The following is a description of a gene set: Reactome Pathway: Epigenetic regulation by WDR5-containing histone modifying complexes <p>WDR5 is a component of six histone methyltransferases and three histone acetyltransferases involved in epigenetic regulation of gene expression.</p><p>The WDR5 histone methyltransferase complexes (KMT2 complexes) include the Mixed Lineage Leukemia (MLL) 1-4, SET1A, and SET1B. All KMT2 complexes consist of a histone methyltransferase (KMT2A, KMT2B, KMT2C, KMT2D, SETD1A, or SETD1B, respectively) and the WRAD subcomplex composed of WDR5, RBBP5, ASH2L, and DPY30. The WRAD complex regulates the enzymatic activity of histone methyltransferases and enables their recruitment to chromatin. Additional transcription cofactors associate with each KMT2 histone methyltransferase complex, enabling their functional diversification. All KMT2 complexes methylate lysine K5 of histone H3 (K4 in mature histone H3 peptides, as the initiator methionine is removed), which is associated with transcriptional activation. Different KMT2 complexes preferentially monomethylate, dimethylate, or trimethylate H3K4, depending on the presence of accessory subunits, transcriptional co-factors, and posttranslational modifications. The KMT2A and KMT2B complexes preferentially methylate H3K4 at a limited number of target gene promoters, while KMT2C and KMT2D complexes preferentially methylate H3K4 at a limited number of target gene enhancers. SETD1A and SETD1B complexes are responsible for the bulk of cellular H3K4 methylation and show less target specificity. For a detailed overview, please refer to Cho et al. 2007, Song and Kingston 2008, Patel et al. 2009, Wang et al. 2009, Takahashi et al. 2011, Couture and Skiniotis 2013, van Nuland et al. 2013, Rao and Dou 2015, Klonou et al. 2021.</p><p>WDR5 is also a component of three histone acetyltransferase complexes, GCN5-ATAC, PCAF-ATAC, and MOF/KAT8-NSL. The role of WDR5 in epigenetic regulation of gene expression through histone acetylation is under investigation.</p><p>The KMT2C (MLL3) complex, together with the related KMT2D (MLL4) complex, is most similar to Drosophila Trr (Trithorax-related) and mediates hitone H3 lysine-4 (H3K4 - lysine 5 in nascent histone H3) monomethylation, with the establishment of the H3K4me1 epigenetic marks, at transcription enhancers throughout the human genome, with estimates ranging from approximately 12,000 to over 20,000 sites, depending on the cell type and developmental stage. While H3K4 monomethylation by MLL3 and MLL4 complexes may not be essential for expression of developmental genes, it is likely important for fine tuning of transcription levels and timing, both during normal development and in cancer. For review, please refer to Hu et al. 2013, Piunti and Shilatifard 2016, Fagan and Dingwall 2019, and Klonou et al. 2021.</p><p>Based on mouse studies, MLL3 and MLL4 complexes play an important role in adipogenesis and myogenesis. During adipogenesis, the KMT2D (MLL4) complex preferentially localizes to active enhancers, marked by the presence of mono- or dimethylated histone H3 lysine-4 (H3K4me1/2, residue K4 corresponds to residue K5 in nascent histone H3), acetylated H3 lysine-27 (H3K27ac), and the presence of RNA Pol II. KMT2D localizes to these active enhancers together with the adipogenic transcription factors CEBPB, CEBPA, and PPARG, and is especially enriched at high confidence enhancers that are both CEBP and PPARG positive.</p> studied in species Homo sapiens part of: Epigenetic regulation of gene expression, and this is the list of marker genes: H2AC20 (NCBI Gene Id 8338), KAT2A, H2BC15, ZZZ3 (NCBI Gene Id 26009), H2AZ2, MED16, HCFC1, CCNC (NCBI Gene Id 892), TADA3, NCOA6, MED12, RB1, H2AC7, BOD1, CD36, MED1, H3C15, PPARG, NCOA3, NCOA1, MED30, PLIN2, DR1, ACSL1, KMT2B, SCD, LIPE, H2AC4, KMT2A (NCBI Gene Id 79951), SETD1B, SGF29 (SAGA complex associated factor 29), SCD5, DGAT2, MEN1, NCOA2, LPL, ADIPOQ, MBIP (NCBI Gene Id 51562), H2AJ, KANSL3, NR5A2, PSIP1, ELOVL5, MED31, ABL1, PHF20 (PHD finger protein 20), NCOR1, CEBPA, AKAP8L, MED24, H3C1, H3-3A, MED10, MED20, KDM6A, GPAM, PAXIP1, KMT2C, H2AX, H2BC5, H2AC18, H2BC12, MED14 (mediator complex subunit 14), H2BC3, CIDEC, CXXC1, H2AC6, H2BC1, OGT, PHLDA1, TADA2A, H2BC26, PDK4, KANSL1, PPARGC1A, GPS2, RBBP5, PLIN4, H2BC14, CDK8, BOD1L1, PHF20L1, MED23, H2BC21, DPY30, MED27, AGPAT2, MED17, HCFC2, MED6, HDAC3, MED7, H2BC11, ACSS3, H2BC9, SIRT1, NCOR2, WDR82, RXRA, TBL1XR1, AJUBA, H2BC17, KAT8, H2BC4, WDR5, MED13, PLIN1, H2AB1, KMT2D (NCBI Gene Id 8085), TASP1, KANSL2, EP300, MCRS1, MED4, FABP4, THRSP, CDK5, H4C1, KAT14, KAT2B, YEATS2, ASH2L, LPIN1, PPARGC1B, SETD1A, PEX11A, PAGR1 (NCBI Gene Id 79447), CREBBP, ANGPTL4, MGLL, PNPLA2, H2AC14 (NCBI Gene Id 8331), H2BC13, H2BC12L, TBL1X